The following is a description of a gene set: Any process that modulates the rate, frequency, or extent of the production of a cytokine that contributes to the immune response. species: Mus musculus Mouse Gene Set: GOBP_POSITIVE_REGULATION_OF_MYELOID_LEUKOCYTE_CYTOKINE_PRODUCTION_INVOLVED_IN_IMMUNE_RESPONSE, and this is the list of marker genes: Syk, Pycard, Kit, Psg22, Ddx1, Tlr3, Card9, Mavs, Mif, Ripk2, Plcg2, Casp4, Tlr7, Fcer1g, Cd36, Nod2, Casp1, Ddx21, Gprc5b (NCBI Gene Id 64297), Tlr4 (NCBI Gene Id 21898), Cd74, H2-M3 (NCBI Gene Id 14991), Tirap, Nod1, Rtn4, Myd88, Rigi, Mir324, Laptm5, Spon2, Tlr2, Panx1, Sema7a (sema domain, immunoglobulin domain (Ig), and GPI membrane anchor, (semaphorin) 7A), P2rx7, Ticam1, Fcer1a, Mapkapk2, Wnt5a, Ifng, Sirt1, Dhx36, Nr4a3